Given this list of marker genes Eif6 (NCBI Gene Id 98777), Adcyap1r1, Ppp4r3b, Clk2, Psen1 (NCBI Gene Id 19164), Nfe2l1, Slc4a4, Lcmt1, Fbp1, P2ry6, Acacb, Ppp1r3g, Cox11, Prkaa2, Hdac4, Zfp692, Pdk1, Sik2, Ep300, Zbtb20, Pth1r, Myc, Ppp1r3e, Ppp1r3b, Ppp4r3a, P2rx7, Prkag3, Prkag2, Ptafr, Lhcgr, Plcd1, Usp7, Ppp1r3f, Ptger4, P2ry1, Cyp2j6, Nupr1, Snca, Erfe, Irs2, Pdk3, Tgfb1, Esrrb, Mup3, Sirt1, Src (Rous sarcoma oncogene), Hmgb1, Sorbs1, Trim63, Dyrk2, Ddb1, Mup5, Sirt6, Stk11, Igf1, Ppp1ca, Avpr1b, Tcf7l2, Nnmt, Adora2b, Gpld1, Ranbp2, Gpt, Htr2a, Pomc, Flcn (folliculin), Igfbp3, Pdgfb, C1qtnf1, Gck, Igf2, Oprm1, Has2, Ncor1, Obp2a, Foxk1, Foxk2, Git1 (NCBI Gene Id 63992), Aldob, Mlxipl, Kat2b, Slc45a3, Myh9, Gnb3 (NCBI Gene Id 14695), Arpp19, Gcg, Bckdk, Dgkq, Rora, Gsk3b (glycogen synthase kinase 3 beta), Nln, Lep, Akt2, Phka1, Slc25a12, Supt20, Jmjd8, Arl2, Mir143, Fgl1, Nr3c1, Sesn2, Pdk4, Nr1h4, Ddit4, Inpp5k, Lepr, Ppp1r3c, Mtch2, Slc4a1, Phkg2, Xpc, Mst1, Gckr, Myog, Sik1, C1qtnf3, Irs1 (NCBI Gene Id 16367), Trp53, Ptpn2, Epm2aip1, Smpd3, Prxl2c, Prkg1, Hsd11b1, Sirt7, Gfpt1, Plek, Arnt, Ier3, Phlda2, Rgn, Midn, Il6, Ppp1r3a, Cltc, Ntsr1, Kat2a, Foxo1 (forkhead box O1), Egf, Enpp1 (ectonucleotide pyrophosphatase/phosphodiesterase 1), Mas1, Adipor1, Gapdhs, Khk, Zmpste24, Trex1, Ppara, Tigar, Ins1, Pgp, Dgat2, Nfkb1, Rptor, Adcy10, C1qtnf2, Ogt, Pth, Cd244a (CD244 molecule A), Pou1f1, Ppp1cb, Tff3, Mup4, Ins2, Pdk2, Phkg1, Serpina12, Prkag1, Ppp2ca, Uchl1, Nkx1-1, Ncoa2, Pfkfb1, Ifng, App, Grb10, Gnmt, Mup1, Cry1, Gcgr, Mlycd, Zbtb7a, Mlst8, Il3, Wdr5, Hif1a, Phkb, Stat3, Gpd1, Acadm, Hnf4a, Pask (NCBI Gene Id 269224), C1qtnf12, Gpi1, Scarb2, Ap2a1, Insr, Ppargc1a, Mup11, Mlx, Slc2a6, Prkn, Igfbp4, Mtcl2, Adra1b, Cbfa2t3, Akt1, Rubcnl, Mup2, Actn3, Gper1, Ppp1r3d, Slc35b4, 1810024B03Rik, Prkaa1, Adipoq, Pmaip1, Prkaca, Rorc, Mtor, here is a description of the gene set: Mouse Gene Set: GOBP_REGULATION_OF_CARBOHYDRATE_METABOLIC_PROCESS species: Mus musculus Any process that modulates the frequency, rate or extent of the chemical reactions and pathways involving carbohydrates.